Given this list of marker genes Ccl27al, Ccl11, Ccl27b, Nars1, Ccl27a, Ccl24, Ccl26, here is a description of the gene set: species: Mus musculus Binding to a CCR3 chemokine receptor. Mouse Gene Set: GOMF_CCR3_CHEMOKINE_RECEPTOR_BINDING